The following is a description of a gene set: studied in species Mus musculus The process in which the anatomical structures of the ureter are generated and organized. The ureter is a muscular tube that transports urine from the kidney to the urinary bladder. Mouse Gene Set: GOBP_URETER_MORPHOGENESIS, and this is the list of marker genes: Lhx1, Pax2, Gata3, Lzts2, Emx2, Mecom, Sox8, Bmp4, Sox9